The following is a description of a gene set: Broad foot studied in species Homo sapiens Human Gene Set: HP_BROAD_FOOT A foot for which the measured width is above the 95th centile for age; or, a foot that appears disproportionately wide for its length., and this is the list of marker genes: FBXO11, TONSL (tonsoku like, DNA repair protein), GPC4, ERI1, POR, GPC3, DYNC1H1, PHF6, DYM, BMPR1B, GPR101, MSL3, FGFR1, PDE4D, NLRP3, CTCF, POGZ, SLC26A2, CCDC28B (NCBI Gene Id 79140), LMBR1, SUZ12, BBS1, XYLT1, AIFM1, CDC42BPB, B3GLCT, ARL6, PTH1R, TBL1XR1, RPL10, EZH2 (NCBI Gene Id 392834), NSD1, MASP1, DLG5, FGD1 (NCBI Gene Id 2245), AIP, GDF6